The following is a description of a gene set: Best corrected visual acuity worse than 1.90 logMAR (roughly 20/1590). Ultra-low vision studied in species Homo sapiens Human Gene Set: HP_ULTRA_LOW_VISION, and this is the list of marker genes: HMX1, BBS2, ATOH7, GDF6, NMNAT1